Given this list of marker genes COL4A2, COL4A5, COL8A2, COL4A3, COL4A1, COL8A1, COL4A6, COL10A1, COL4A4, here is a description of the gene set: Human Gene Set: GOCC_NETWORK_FORMING_COLLAGEN_TRIMER A collagen trimer that forms networks. species: Homo sapiens